Given this list of marker genes Prkcz, Hmgb1, Socs1, Irf1, Ripk2, Loxl3, Tgfb1, Stat3, Braf, Ly9, Gpr183, Ccl20, Rsad2, Opa1, Ascl2, Men1, Il4ra, Il2ra, Armc5, Tcirg1, Tgfbr2, Il18r1, Stoml2, Tnfsf4, Lgals1, Lgals9, Sema4a, Ager, Cebpb, Gimap5, Nfkbid, Runx3, Cdh26, Il23a (interleukin 23, alpha subunit p19), H2-Ea, Hlx, Socs5, Tbx21, Zbtb7b, Zc3h12a, Cd3e, Foxp1, Ep300, Rc3h1, Cd83, Nlrp3, Rora, Il21, Atp7a, Gadd45g, Ccr7, Twsg1, Il27, Vsir, Gimap3, Brd4, Xcl1, Pax1, Gata3, Il12a, Ndfip1, Smad7, Il2rg, Relb, Anxa1, Tarm1, Mtor, Pla2g2d, Cracr2a, Mir873a, Zfp35, Irgm1, Cd81, Pf4, Ifng, Shb, Il12b, Sh3rf1, Cd274 (NCBI Gene Id 60533), Nkg7, Cblb, Il18, Gimap1, Ccl19, Cd24a, Ncor1, Il4, Sash3, Tbk1, Batf (basic leucine zipper transcription factor, ATF-like), Tnfsf18, Bcl6, Ptger4, Spn, Tox, Stat6, Nkx2-3, Tnfrsf14, Irf4, Rara, Nckap1l, Ctsl, Myb, Ccr2, Otud5, Mir301, Jak3, Slamf6, Prkcq, Arg2, Cbfb, Il6ra, Lilrb4a, Kmt2a, Stat4, Cd44, Runx1, Fut7, Rorc, Foxp3, Nfkbiz, Card11, Lef1, Il6, Cd69, Tmem98, Cd28, Rc3h2, Itch, Il2, Kcnk18, Entpd7, Satb1, Mir326, Malt1, Brd2, Klhl25, Cd55b, Cd55, Bcl3 (B cell leukemia/lymphoma 3), Pik3r1, Cd160, Ccr6, here is a description of the gene set: studied in species Mus musculus Mouse Gene Set: GOBP_CD4_POSITIVE_ALPHA_BETA_T_CELL_ACTIVATION The change in morphology and behavior of a CD4-positive, alpha-beta T cell resulting from exposure to a mitogen, cytokine, chemokine, cellular ligand, or an antigen for which it is specific.